Given this list of marker genes RNF182, RPL6P17, MCUR1, RN7SL332P, ENSG00000237346, MRPL35P1, GFOD1-AS1, RANBP9, ENSG00000272209, RNU7-133P, RN7SKP204, SIRT5, LINC01108, NOL7, GFOD1, RPS4XP7, CD83, RNU6-793P, here is a description of the gene set: studied in species Homo sapiens Human Gene Set: chr6p23